Given this list of marker genes ME1, ABCC1, SOD3, ABCG2, PSMB3, PSMB6, PSMC5 (proteasome 26S subunit, ATPase 5), PSMA1, PSMA5, UBC, BCL2L1, HMOX1, AREG, PSMC4, PSMB7, SP1, GSTA1, PSMA4, BTRC, UBA52, GCLC, PRKAA2, TXNRD1, TKT, ADRM1, TALDO1, PSMD2, SQSTM1, CREBBP, CDKN2A, BCL2, RBX1, PSMD7, MAFK, PSMD3, PSMC6, PSMD1, PSMC2, RPS27A, PSMA2, PSMB5 (NCBI Gene Id 5693), PSMD13, CUL1, ATF4, NFKB1, PSMD11, CHD6, NQO1, PSMA3, RELA, GSR, PSMA7, PGD, NFE2L2, PSMB2, BACH1, UBB, PSMC3, GSTA3, PSMD14, TXN, SEM1, ABCC3, KEAP1, G6PD, ABCF2, SLC7A11, GSK3B, PSMB4, EGF, PSMD6, PSMD12, IL8, PDGFA, MYC, PSMA6, GCLM, MAFG, PRDX1, NOTCH1, CCL2, SKP1, PSMB1, PSMD8, IDH1, EP300, PSMC1, SRXN1, here is a description of the gene set: In response to chemical and other stressors, the constitutive degradation of NFE2L2 by the KEAP1:CUL3:26S proteasome system is disrupted, allowing NFE2L2 to accumulate. Stabilized NFE2L2 translocates to the nucleus where it binds to antioxidant response elements (AREs) in the promoters and enhancers of target genes to upregulate their expression. part of: KEAP1-NFE2L2 pathway species: Homo sapiens Reactome Pathway: Nuclear events mediated by NFE2L2